The following is a description of a gene set: Human Gene Set: MORF_G22P1 Neighborhood of G22P1 NULL in the MORF expression compendium Neighborhood of G22P1 studied in species Homo sapiens, and this is the list of marker genes: BTF3, YBX1, EID1, NDUFS4, LSM7, RPL24, AP2M1, DYNLL1, MRPL23, EIF4G2, TRIM28, STARD7, NSA2, IMPDH1, SUMO2, PSMD8, YWHAQ (tyrosine 3-monooxygenase/tryptophan 5-monooxygenase activation protein theta), GDI2, CCT2, CLNS1A, SDHB, NDUFS3, EIF3M, EIF3C, ELOC, SRSF3, KXD1, NDUFS5, ERH, SNRNP200, POLR2I, HDGF, NARS1, ATXN10, SMC1A (structural maintenance of chromosomes 1A), HNRNPUL1, NDUFV1, HNRNPM, XRCC5, CCT7, NPM1, CTBP1, SLC25A3, EIF3H, BAG6, NONO, SAMM50, ATP1B3, GANAB, VDAC2, ANP32B, USP22, EIF3K (NCBI Gene Id 55373), TARDBP, RBM14, HNRNPA1, HNRNPA3P1, ATP5F1A, HDAC1, RAN, SRSF9 (NCBI Gene Id 8683), NDUFV2, SRSF2, CDC123, SNRPA, HNRNPD, PARK7, STRAP, PRMT1, HSP90AA1, CTDNEP1, HMGN1, CDV3, SRP14, XRCC6, CHD4, JTB, DHX9 (NCBI Gene Id 3450), SET, MDH1, FBL, EIF3I, RBMX, UBA2, PSMB1, ILF2, WDR1, CSNK2B, COX4I1, NUDT1, PSMA4, COMMD4, FAU, TRA2B, PCMT1, H2AZ1, ANAPC5, HSP90AB1, H2AZ2, DHX15, LSM2, ZNF207, SNRPE (NCBI Gene Id 6635), PTBP1, MYL6B, PPM1G, TCP1, EIF3G, UQCRH, MAEA (macrophage erythroblast attacher, E3 ubiquitin ligase), SNX3, KARS1, EIF4A1, ATP5MC3, ATP5PO, SNRPD2, AP3D1, PSMB3, MCM7, NDUFAB1, PGK1, IDH3B, UBE2I, SNRPB2, KHDRBS1, TXNL4A, IFT25, DDX49, PSMB7, RAD23A, DRG1, COX7C, AP1B1, TUFM, COX6B1, ACLY, SF3A1, CDC37, BUB3, CLIC1, RNPS1, PCNA, GPN1, PUF60 (poly(U) binding splicing factor 60), HADHA, CCT3 (NCBI Gene Id 7203), UQCRB, NAP1L1 (nucleosome assembly protein 1 like 1), SUMO3, FAM168B, COX5B, NACA, HSPD1, EIF3D, NCL, TOMM20, UBE2L3, RPL14, SNRPB, ACP1, HNRNPC, SRP9, PHB2, UQCRFS1, EIF4H, U2AF1, ATP5MC1, DEK, CBX3, PDIA6, FUS, TTC1